The following is a description of a gene set: species: Homo sapiens A protein-DNA complex assembled at eukaryotic DNA replication origins immediately prior to the initiation of DNA replication. The preinitiation complex is formed by the assembly of additional proteins onto an existing prereplicative complex. In budding yeast, the additional proteins might include Cdc45p, Sld2p, Sld3p, Dpb11p, DNA polymerases, and others; in fission yeast the GINS complex is present. Human Gene Set: GOCC_DNA_REPLICATION_PREINITIATION_COMPLEX, and this is the list of marker genes: ORC3, MCM5, MCM3, MCM4, GINS1, SLC5A8, CDC45, GINS4, MCM2, MCM6, GINS2, GINS3, MCM7